Given this list of marker genes CHIC1, GNAI1, LMAN1, NUP43, ASAP2, DBN1, CWF19L1, SEPHS1, ITGBL1, DYRK1A, THADA, EME1, DNAJB4, CHM, ARFIP1, ONECUT2, SLC32A1, ANK1, SSR2, TFF2, MOB1B, KERA, TPH2, OSBPL6, EHBP1, WAC, MEF2C, NF1, ZNF586, EHHADH, PHC1, QKI, DNAJC12, LOX, SH3TC2, MTF1, LRRC28 (NCBI Gene Id 123355), RTKN2, SEC62, XKR4, FAM240A, SPPL3 (signal peptide peptidase like 3), PURA, BICD2, GLOD4, GRHL1, LRIT2, GPR171, EFHC2, BACE1 (NCBI Gene Id 23621), PTGDR, SRGAP1, TNFRSF9, CLIP4, EMP2, M1AP, CEP20, S100Z, CLOCK, RAPGEF2, PREX2, FBXW10B, GLRB, SHISA9, SYT4, CUX2, SLC9A9, ANK2, SEPTIN10, KLHL6, SPAM1, ACBD3, HDHD2, ZNF146, ATP6V0D2, OPRM1, DNALI1, AXIN2, RNF19B, SEMA6A, ADAMTS17, HUWE1, EPC2, WDR77 (NCBI Gene Id 79084), ASXL3, ZNF773, ATOSA, ERC1, KDM5A, ZKSCAN7, GOLIM4, RIMBP2, TM9SF2, KATNBL1, N4BP2L2, BEND4, CBFA2T3, LPP, ADRB3, LRRTM2, RIMS2, TESK2, NEO1, ANGPT2, SGTB, FOXA2, DCX, DPP10, CRISPLD1, MYL2, CPEB2, CTTNBP2NL, GTF2I, MAP3K20, NRP2, PTPRT, PRKACB, DCLK1 (NCBI Gene Id 9201), GRK5, SRSF1, YTHDF3, LIX1, COLCA1, PTGFRN, TBC1D4, PJA1, CRTC1, SYT14, DMAC1, RTL3, SMIM21, DYNC1I1, FBXO3, ANKRD28, FAXC, JARID2, NUDT4, VIM, here is a description of the gene set: Genes predicted to be targets of miRBase v22 microRNA hsa-miR-876-5p in miRDB v6.0 with MirTarget v4 prediction scores > 80 (high confidence targets). Human Gene Set: MIR876_5P species: Homo sapiens from publication Chen Y, Wang X (PMID 31504780)